Given this list of marker genes PAX4, ITCH, DUT, KCNJ11, FCGR2C, FOXP3, PDCD1, here is a description of the gene set: The presence of autoantibodies (immunoglobulins) in the serum that react against glutamic acid decarboxylase. Anti-glutamic acid decarboxylase antibody positivity Human Gene Set: HP_ANTI_GLUTAMIC_ACID_DECARBOXYLASE_ANTIBODY_POSITIVITY studied in species Homo sapiens